The following is a description of a gene set: studied in species Homo sapiens Human Gene Set: MIR2115_5P from publication Chen Y, Wang X (PMID 31504780) Genes predicted to be targets of miRBase v22 microRNA hsa-miR-2115-5p in miRDB v6.0 with MirTarget v4 prediction scores > 80 (high confidence targets)., and this is the list of marker genes: TFCP2L1, LPGAT1, JAG1 (jagged canonical Notch ligand 1), RPS6KB1, DPH3P1, TEX26 (NCBI Gene Id 122046), DTX3L, TXNDC12, BTBD7, CDKN2D, LENG8, ARID4A, TET3, FAT3, AMER3, ABHD17A, UBE2U, CFAP90, IQSEC2, ZKSCAN2, USP49, KCNIP1, PHF20, CXADR, GPR176, CD274, SAP130 (NCBI Gene Id 79595), WWOX, FAM83B, TTPAL, PLA2R1, CSNK1G3, MAMSTR, NACA, JAZF1 (NCBI Gene Id 94314), ATL3, KLRK1, ORC5, NFATC2, HSF5, TMBIM4, SSBP3, ENSG00000228919, CYLD, MIER3, ADAMTS17, VANGL1, ZFPM2 (NCBI Gene Id 56958), PEX5L, ONECUT2, MAF (NCBI Gene Id 4094), GXYLT1, SH3BP5, KIF21B, PRKCA, ACLY, BORCS5, TTC7A, MTA3, NGF, DHRS12, KLF6, IQGAP1, ARHGAP19, SGK1, CORO2B, RPIA, ZFP91, CEP170, BTF3L4, SNRNP27, MBTPS1, MRPL34 (mitochondrial ribosomal protein L34), SFT2D2, GABRG3, SPDYA, TFAP2A, MID2, RUBCN, HMBOX1, GOSR2, NPY2R, TAF5, RCBTB1, IDS, CBLL1, IRS1, STC2, ZNF266, TRIP13, ANTXR1, SREK1, CADM2, NPAS3, TMEM164, REPIN1, DPH3, AFF1 (NCBI Gene Id 83116), RC3H2, ZC2HC1C, TMEM37, CNNM4, ZNF367, HNRNPA0 (NCBI Gene Id 10949), TCF7L2, KIFC3, KIAA1549, VGLL3, RFWD3, PIK3R3, B3GAT1, TEAD1 (NCBI Gene Id 8), SPRED1, BORCS7, ATXN2, ELL2, MARF1, HSPA12A, PIK3C2A, PKP4, LRATD2, HMGN3, CRKL, RBM20, DRP2, RAB8B (RAB8B, member RAS oncogene family), TES, DOCK3, RAB10, NAV2, TULP4, PURB, ZFAND5, LTN1, CERS6